Given this list of marker genes HRH2, HRH3, HRH4, HTR6, ZNF219, HRH1 (histamine receptor H1), here is a description of the gene set: studied in species Homo sapiens Human Gene Set: GOMF_HISTAMINE_RECEPTOR_ACTIVITY Combining with histamine to initiate a change in cell activity. Histamine is a physiologically active amine, found in plant and animal tissue and released from mast cells as part of an allergic reaction in humans.